The following is a description of a gene set: Dendritic cells (DCs) are the sentinels of the mammalian immune system and they undergo a complex maturation process mediated by activation upon pathogen detection. Recent studies described the analysis of activated DCs by transcriptional profiling, but translation regulation was never taken in account. Therefore, the nature of the mRNAs being translated at various stages of DC activation was determined with the help of translational profiling, which is the sucrose gradient fractionation of polysomal-bound mRNAs combined to microarrays analysis. Total and polysomal-bound mRNA populations were compared in immature (0h) and LPS-stimulated (4h and 16h) human monocyte-derived DCs with the help of Affymetrix microarrays. Biostatistical analysis indicated that 296 mRNA molecules are translationally regulated during DC-activation. The most abundant biological process among the regulated mRNAs was protein biosynthesis, indicating the existence of a negative feedback loop regulating translation. Interestingly, a cluster of 17 ribosomal proteins were part of the regulated mRNAs, indicating that translation may be fine-tuned by particular components of the translational machinery. Our observations highlight the importance of translation regulation during the immune response, and may favour the identification of novel gene clusters or protein networks relevant for immunity. Our study also provides information on the possible absence of correlation between gene expression and real protein production in DCs. Genes down-regulated in comparison of polysome bound (translated) mRNA before and 4 h after LPS (TLR4 agonist) stimulation. Human Gene Set: GSE14000_UNSTIM_VS_4H_LPS_DC_TRANSLATED_RNA_DN studied in species Homo sapiens from publication Ceppi M, Clavarino G, Gatti E, Schmidt EK, de Gassart A, Blankenship D, Ogola G, Banchereau J, Chaussabel D, Pierre P (PMID 19943945), and this is the list of marker genes: CFLAR, HOMER1, CCKAR, SOCS3, TMEM74B, USP18, APOL6, GBP5, CTXN1, SP110, OVOL3, ETV7, RTP4, BIRC3, LILRB3, PMAIP1, DACT3, IFIT1, MIR155HG, IFIT3, HERC6, DRAM1, USP25, IRAK2, CACHD1, FSD1L, PLAT, ELF4, PNPT1, TNFAIP6, NUPR1 (nuclear protein 1, transcriptional regulator), GBP2, ATP6V1G3, CD38, PLS3, IFIT5, CCL5, ZC3H12C, CA13, SOD2, SFT2D2, STAT1, MFN1, APOBEC3G, IRF1, HERC5, LINC01588, ERRFI1, BRIP1, NEURL3, BATF2, TENT4A, F3, TRIM26, NAMPT, UBE2L6, VEGFC, IFI44L, DYNLT1, USP2, SGPP2, DBH-AS1, IFI27, OASL, C1GALT1, ISG15, SERPING1, GCH1, TOR1B (NCBI Gene Id 84822), NR4A3, TMEM268, MX2, PTGER4, RSAD2, IFITM1, IL15RA, PLPPR2, BLZF1 (basic leucine zipper nuclear factor 1), ACSL1, CMPK2, RHEBL1, MT1HL1, TTC39B, SDR9C7, NLRC5, DCP1A, IDO1, ADPRM (NCBI Gene Id 56985, ADP-ribose/CDP-alcohol diphosphatase, manganese dependent), ZNF32-AS3, GTPBP1, SLFN5, TRIM69, IL1B, SELENBP1, CDK17, RAB29, DNAJC22, MAPK11, LINC01191, TNFSF15, MYD88, PI4K2B, FERMT2, XAF1, ISG20, TRAF1, CYP27B1, DNAAF1, ATF3, IFIT2, DTX3L, STX11, PARP9, SLC41A2, FUT4, MTHFD2, GPD2, CGAS, NUB1, TNFSF10, CCL4, TDH, IRF7, DUSP5, RIGI, BCL2L14, EPSTI1, APOBEC3A, WARS1, FAM135A, CD80, BCL2A1, SLC31A2, MCOLN2, TCF7L2, CSRNP2, NXN, TNIP2, ATF5, SRGAP2C, IFIH1, IFI44, NIM1K, CSRP2, NFKBIZ, IGLON5, DDN, LY6K, MASTL, FNDC5, RECK, MICB, NT5C3A, CCL1, CKAP4, NCOA7, AIM2, MX1, SLAMF7, ATP10A, CR1L, CD274, HS3ST3B1, MELK, IL15 (NCBI Gene Id 3600), USP42, ADAMTS10, CDKL1, CELA1, DEFB124, DDX60L, CCL8, CARINH, PPM1K, NEMP1, CXCL11, OAS2, ARHGAP22, OSM, CD48, BMP2 (bone morphogenetic protein 2), LILRA3, GBP1, ADGRL3 (adhesion G protein-coupled receptor L3), POM121L12, PDGFRL, HOXB1, SLC25A28, CASP7, OAS1, GRHL1, GRB10, ITGB8, GMPR, ZNF107 (NCBI Gene Id 7660), TRIM56, CNP